The following is a description of a gene set: Human Gene Set: GOBP_REGULATION_OF_PROTEIN_LOCALIZATION_TO_ENDOPLASMIC_RETICULUM species: Homo sapiens Any process that modulates the frequency, rate or extent of protein localization to endoplasmic reticulum., and this is the list of marker genes: DDRGK1, NACA, RTN4, AKT1, BTF3